Given this list of marker genes Tfap2c, Nup153, Slc15a4, Slc52a2, Amy2a3, Amy2a4, C1s2, Amy2a2, Trp53inp1, Dcaf7, Rapgef6, Zeb2, Zfp945, Nalcn, Ctcf, Rnf138, Abl2, Cbln2, Brinp3, Slc16a6 (solute carrier family 16 (monocarboxylic acid transporters), member 6), Defb20, Purb, Rpia, Txndc12, Strbp, Slit2, Ubr3, Cldn34b2, Adi1, Adra1b, Cnot1, Tcf21, Eaf1, Ddx3x, Smpdl3b, Casp3, Gnao1, Gid4, Krr1, Ubxn7, Dnmt3b, Ofd1, Cnst (NCBI Gene Id 226744), Dlst, Pwp1, Tle1, Mpv17l, Sh3rf1, Cldn34b1, Alg8, Api5, Zbtb10, Syn3, Vdac1, Nufip2, Jun, Kdm5a, Prdx1, Nemp1, Atg12, Hrh3, B4galt1, Abi2 (NCBI Gene Id 98436), Rasgrp1, Ints14, Tfap2e, Slc9a2, B230219D22Rik (NCBI Gene Id 78582), Abo, Trabd2b, Nrip1, Mtus1, Syt14, Ccn2, Gata4, Meioc, Mysm1, Thumpd3, Eya1, Mgat4a, Arl13b, Hycc2, Slc25a20, Cse1l, Elavl3, Ino80, Ppm1h, Gnptab, Sycp3, Arhgef2, Foxb1, Ikzf5, Slc23a2, Atg16l1, Fhl2, Rbm20, Rcbtb2, Tbl1x, Knstrn, Ing3, 2410004B18Rik, Or52a5b, Casz1, Kif3b, Map3k2, Tmem263, Timm17b, Ppp2r3a, Cldn34b3, Slc16a13, Cops7b, Slc1a3, Socs6 (suppressor of cytokine signaling 6), Etnk1, Mxi1, Zfp160, Mylk4, Pgm2, Hopx, Canx (calnexin), Dyrk1a, Mta1, Gabrg1, Sirt1, Ube2e2, Taf12 (TATA-box binding protein associated factor 12), Zfp235, Trp53inp2, Rimoc1, Leprot, Mlec, Itga9, Dnajb9, Ogt, Wdr20rt, Ap1s2, Uck2, Dcbld2, Irx2, Skp2, Il1r1, here is a description of the gene set: Genes predicted to be targets of miRBase v22 microRNA mmu_miR_873b in miRDB v6.0 with MirTarget v4 prediction scores > 80 (high confidence targets). Mouse Gene Set: MIR_873B from publication Chen Y, Wang X (PMID 31504780) species: Mus musculus